The following is a description of a gene set: studied in species Homo sapiens Human Gene Set: REACTOME_CYTOCHROME_C_MEDIATED_APOPTOTIC_RESPONSE Cytochrome c-mediated apoptotic response, and this is the list of marker genes: DIABLO, MAPK1, AVEN, CYCS, MAPK3, XIAP, UACA, APAF1, CASP3 (NCBI Gene Id 836), APIP, CASP7, CASP9, CARD8